The following is a description of a gene set: The lipid bilayer surrounding an endosome. Mouse Gene Set: GOCC_ENDOSOME_MEMBRANE studied in species Mus musculus, and this is the list of marker genes: Cd300lg, Clip3, Vps52, Vps37a, Osbpl9, Vps53, Snx4, Ncdn, Fgd2, H2-Q1, Zdhhc1, Eea1, Ap5s1, Zdhhc2, H2-Eb2, Atg16l1, Zdhhc11, Cd274, Vps25, H2-Ea, Baiap3 (NCBI Gene Id 545192), Scamp3, Atp8a2, Atp7a, Vps33a, H2-M10.6, Tmem150b, Tasl, Tmem59 (transmembrane protein 59), Tlr8, Ifitm3, Rab10, Mtmr2, Cc2d1b, Atp11b, Becn1, Rab7, Uba1, Amn, Plpp2, Arl8b, Epha8 (Eph receptor A8), Slc35d3, Bok, Scamp1, Snx25, Slc15a4, Inpp5b, Appl1, Mvb12b, Snx12, Marchf1 (membrane associated ring-CH-type finger 1), Slc30a10, Ehd3, Marchf8, D130043K22Rik, Anp32e, Tmem63a, Pld1, Sppl2b, Kcnh1, Gga2, Ap3d1, Vps4a, Gripap1, Mon2, Tlr9, Rab14, Insr, Diaph3, Clcn5, H2-Oa, B2m, Stard3nl, Slc9a7, Slc5a7, Thsd1, Washc5, Arc, Tmem108, Grb14, Snx21, Washc3, Gria1, Tbc1d5, Pml, Dnajc13, Cd1d2, Hps6, Slc30a4, Vps37b, Arf6, Gpr61, Tfrc, Abcc5, Tab2, Rufy1, Vps33b, Slc9a3, Snx8, Atg9b, Dagla, Or51e2, Slc36a2, Dll3, Rab21, Rnf13, Chmp6, H2-Eb1, Leprot, Arhgap26, Mical1, Inpp4a, Nsg1, Steap1, Vps35, Pld3, Micall1, Tm9sf2, Vps13a, Dtnbp1, Snf8, Kir3dl2, Napepld, Tlr3, H2-D1, Notch1, Yipf1, Rep15, Spns2, Clvs1, Htr4, Slc11a2, Plin3, Myo5b, Rab11a, Cd1d1, Vps28, Stam, Cptp, Vps13c, Egfr, Snx2, Stam2, Litaf, Fig4, Tom1l1, Galntl5, Ret, Dop1b, Arhgap1, Ap1g2, Chmp1b, Snx10, Pigr (NCBI Gene Id 18703), Steap2, H2-Q10, Erbb2, Rffl, Rab15, H2-DMa, Cd68, Pmepa1, Pla2g4b, Scamp5, Cd164, Atp6v0a2, Wipi1, Vps18, Rnf167, Snx30, Ndrg1, Commd1, Slc9a8, Vamp3, Psen1, Atg9a, Plekhm2, Nsg2, Rab4b, Clcn3, Vta1, Zfyve16, Sbf2, Ubap1l, Pmel, Sh3gl3, Aqp2, Fcgrt, Pip4p1, Vps16, Mcoln2, Rabepk, Ehd4, Rilp, Mfsd8, H2-DMb2, Dcstamp, Hsd17b6, Ticam2, Abcb11, Usp8, Vps37d, Wdr44, Clvs2, Slc46a2, Aqp4, Znrf2, Abca5, Gpnmb (glycoprotein (transmembrane) nmb), Osbpl6, Zfyve28, H2-M2, Vps45, Sorcs2, Tyrp1, Gimap5, Scamp4, Wls, Snx6, Abca7, Ifitm2, H2-Aa, Rab5a, Ifitm7, Ankfy1 (ankyrin repeat and FYVE domain containing 1), Kif13a, Tmem175, Rhob, Mcoln1, Abhd6, Gga3, Abhd17b, Mkln1, Lamtor1, Abcg4, H2-M10.4, Gosr2, Kif16b, Ldlr, Abhd17a, Igf2r, Rab11fip2, Pla2g4e, H2-Q7, Slc11a1, H2-M10.1, Sppl2a, Sun2, Entrep1, Atp9a, Dio3, Cmtm6, Zfyve9, Cc2d1a, Mitd1, Neu3, Tlr13, Rhov, Abca3 (ATP-binding cassette, sub-family A member 3), Chmp2a, Slc39a14, Chmp5, Gnpnat1, Slc30a3, Oca2, Snx7, Cln3, Washc2, Slc31a2, Rab27a, Rab17, Ffar4, Slc9a6, H2-Ab1, Rab8b, Irgm1, Ntrk2 (NCBI Gene Id 77471), Vps26a, Snx18, Plekhf2, H2-DMb1, Slc9a9, Rab11b, Tmem63b, Stx6, Slc26a7, Vti1a, Mr1, Rcc2, Hgs, Snx17, Rab5b, Pi4k2a, Clec16a, Appl2, Treml4, Npc1, Tsg101, Pacsin2, Dtx3l, Rap2a, Vps4b, Parm1, Tmem106b, Numb, Syt11, Scyl2, H2-Q6, Pi4k2b, Abca2, Rab5c, Arl8a, Spaar, Slc46a1, Tmem163, Slc6a4, Laptm4a, Itch, Ldlrad4, Chmp7, H2-Ob, Slc38a9, Ocrl, Ube2d3, Ctsd, Akap5, Mmgt1, Slc15a3, Mcoln3, Abhd17c, Snx16, Vps36, Atp13a4, Vti1b, Sort1, Slc30a2, Wdr81, Uevld, Ehd2, Cd63, Pip5k1c (NCBI Gene Id 18717), Steap4, Rab11fip3, Slc26a9, Atp10b, Washc4, Ntrk1, Cyb561a3, Stx12 (syntaxin 12), Tmbim1, Pip4p2, Ndfip1 (Nedd4 family interacting protein 1), Mmgt2, Atp6ap2, Arhgap10, Anxa2, Ap5m1, H2-M5, Stard3, Snx14, Stoml1, Slc39a4, Rab35, Tspan15, Steap3, Snx5, Snx20, Chmp3, Rac1, Chmp1a, Slc31a1, Ubap1, Sh3gl1, Tlr7, Marchf2, Abcb6, Clcn6, Lamp3, Gpr62, Slc48a1, Itm2b, Slc9a5, Stx8, H2-T22, Rab8a, Gga1, Ticam1, Washc1, Acap1, Rab4a, Rab23, Syndig1, Rmc1, Rab11fip5, Chmp2b, Atp11c, Tlr4 (toll-like receptor 4), Zmpste24, Sorl1, Golim4 (NCBI Gene Id 73124), Mreg, Lamp5, Vps39, Atp13a5, Mmd, Vps13b, Rab13, Atp6ap1, Elapor1, Vamp8, Eps15, Chmp1b2, Atp13a2, Rab22a, Vamp4, Vps41, Clcn4, Pikfyve, Snx13, Slc9b2, Mapkap1, Laptm4b, Yipf2, Kir3dl1, Plekhm1, Tmem165, Plekhb2, Snx3, Tpcn1, Vopp1 (NCBI Gene Id 232023), Lztr1, Chmp4b, Stx7, Marchf3, Tmem45b, Snx27, Traf3, Tmem9, Rbsn, Vac14, Pdlim4, Arhgap32, Tmem9b, Litafd, Anxa6, Mrc1, Scamp2, Ephb1, Rap2c, Rab27b, Mvb12a, Tom1, Rab11fip4, Tpcn2, H2-M11, Vps29, Fzd7, Lamp2, Wdr91 (NCBI Gene Id 243752), Syt5, Snx1, Cdip1, Osbpl11, Lamtor3, Rap2b, Fcmr, Gpr135, Mtmr4, Lamtor5, Vps11, Ncf4, Furin, Rnft1, Lamtor2 (late endosomal/lysosomal adaptor, MAPK and MTOR activator 2), Zfyve27, Atp13a3, Ubxn6, Slc29a3, Myo1b, Cftr, Rab12, Tmem30a, Lamtor4, H2-Q2, Coro1c (NCBI Gene Id 23790), Chmp4c, Epha4, Ehd1, Praf2, H2-M10.2, Llgl1, Dync1li1 (dynein cytoplasmic 1 light intermediate chain 1), Lamp1, Shc1, Acap2, Tmem184a, Anxa1, Anxa8, H2-K1, Slc1a1, Sphk1, Vps37c